Given this list of marker genes MT-ATP6, CACNA1A, CFC1, ATXN1, PTCH2, MT-ND5, MT-ND2, IGF2R, GJC2, MPL, LHCGR, KIT, ACVR1B (NCBI Gene Id 93351), TLR3, LIG4, ATXN10, FGF23, BUB1B, AIP, HDAC4, CDH1, MSR1 (NCBI Gene Id 4481), HNRNPDL, MN1, PKD2, PDGFRL, CTLA4, FOXE3, DLST, IFIH1, KMT2C, NPRL2, RB1CC1, GLI2, PTPRJ, CEBPA, IGF2, MSH3, WWOX, SMO, VMA21, SCN4A, PAX7, TSC1, POLR2A, BUB1, OTULIN, RAD54B, MT-CO3, NPM1, UBA1, SHH, PIGT, INAVA, BCR, HMMR, FIGLA (folliculogenesis specific bHLH transcription factor), GATA2, POU6F2, EGFR, PDGFB, KMT2B, TRPV4, MAD1L1, ACTB, BMPR2, GPC3 (glypican 3), MT-ND4, LRRK2, SRC, SIX3, NRL, PPP2R1B, POT1, RPS29, PICALM, ATXN2, FGFR3, TERC, RUNX1, SMAD6, PROK2, PROKR2, JAK2, TAL1, NRIP1, EIF2AK1, SLC12A5 (solute carrier family 12 member 5), PPM1D, SDHB, AXIN2, MT-ND6, ZFHX3, PIGA, ASCC1, ETV6, GJB1, LZTR1, TLR2, TP53, MYD88, PARN, GABRG2, NEK9, ATL1, ATXN7, BAX, ABL1, COL4A2, SPAST, THAP1, IKZF1, GREB1L, PIK3R2, SLC35A2, TENM4, UCHL1, C1GALT1C1, CHRNA4 (NCBI Gene Id 1137), RBM12, ERBB3, MINPP1, RB1, MFN2, DICER1, NLRP12, TGFBR1, PRRT2, CDC73, IL1RN (NCBI Gene Id 3557), MLLT10, EPHB4, CACNB4, LRP5, CHIC2, TFE3, NQO2, MCC, TSC2, EXT1, SCN1B, TET2, PRPF8, PIK3CA, CHRNA2, CCND1, CAV1, DSTYK, RNF6, BRCA2, GPR161, EP300, SRGAP1, SUFU, MYC, CALR, KLF13, PAX3, SGCE, DCC, RORB, GPC4, MT-ND4L, IRF1, KRAS, ELP1, PTEN, IL1B, TAL2, ERBB2, PDGFRA, GNB2, PLA2G2A, SLC22A18, ASXL1, PTCH1, MET, DCHS1, MKRN3, ANO3, CHEK2, OPCML, ATP11A, VWF, PAX6, CPOX, SMARCE1, HCN1, CRELD1, MLH3, FLCN, PAX2, NF2, ATP1A3, HRAS, CHD8, FASLG, SMARCB1, FOXO1, RTEL1, RANBP2, MUTYH, RP1L1, AURKA, RPS14, PRPF31, MNX1, SF3B1, TOR1A, IL6ST, NPRL3, KANK1, PITX1, KIF5A, IL6, ACTN4, FGFR2, DLX5, CTHRC1, PLAG1, WT1, ATM, LRSAM1, TGFBR2, BRCA1, WNT10B, CILK1, NR5A1, USP48, ARHGAP26, CREB1, GUCY2D, XRCC3 (NCBI Gene Id 7517), ATN1, TTN, CASP8, ESR1, RARA, KIF11, RHOA, RAD54L (NCBI Gene Id 8438), NR4A3, PTPN12, CTNNB1, KLF6, CACNA1S, GJA8, GNAI2, RAD51, SMAD4, MT-CYB, CDH23 (cadherin related 23), BARD1, ATXN3, STK11, LZTS1, ARMC5, SLC2A1, MT-ND1, TAF15, PHB1, FMR1, ATP1A2, MAPK1, SIX1, CYP2A6, APC (NCBI Gene Id 324), GNAS, CHRNA7, OPA1, KANSL1, RELN, KIF1B, MXI1, ERCC6 (ERCC excision repair 6, chromatin remodeling factor), DDX41, MSH6, ADA, DZIP1, PTPN11, DNMT3A, GNB1, PRKN, BRIP1, SH3GL1, FLT3, NRAS (NRAS proto-oncogene, GTPase), NF1, AKT1, SH2B3, SEMA6B, CLCN2, CBL, DCX, SMAD9, SMARCC1, COL4A1, JAG1, FH, STAT1, DEPDC5, BRAF, TBK1, SRD5A2, KRIT1, TM4SF20, POF1B, TICAM1, CASP10, AXIN1, TERT, ELOVL4, PRCC, TMEM151A, EYA1, NBN, NUP214, MTOR, MAP3K8, ASPSCR1, ZBTB7A, IDH1, DLC1, FGFR1, GJA5, GABRB3, H19, PRKCG, LPP, GRIN2A, GATA5, BCL10, NTN1, EWSR1, here is a description of the gene set: Human Gene Set: HP_INHERITANCE_QUALIFIER Inheritance qualifier The terms in this hierarchy can be used to specify the context in which inheritance of a disease is typically observed. species: Homo sapiens